Given this list of marker genes Pin1, Fam199x, Cldn12, Rnmt, Pwp1, Tnik, Wdr3, C1d, Wdr11, Rfx3, Zranb2, Pex7, Ppp2r1a, Hnrnpa1, Lsm7, Patz1, Ssbp1, Ppp4r3b, Prim1, Ttc9c, Ndufc2, Eri2, Trp63, Immp1l, E2f7, Appbp2, Bclaf3, Cenpf, Pspc1, Pbk, Hnrnpu, Pigf, Lsm5, Mbnl3, Tasp1, Zik1, Ska2, Mphosph8, Wee1, Snapin, Tmem230, G3bp2, Sap30, Gm42151, Ddr1, Ube2d2a, Actr3b, Srsf3, Plcb1, Ttf2, Smarca5, Nup85 (NCBI Gene Id 445007), Pabpc4l, Xpo1, Idh3a, Snrpb2, Trpm3, Snx5, Trappc2b, Cstf2, Itga2, Prr14l, Ctcf, Ndufa4, Ctnnd2, Hnrnpa2b1, Plekhb1, Rnf6, Bub1, Rragd, Ercc6l2, Eif4h, Esco2, Kbtbd8, Mcm2, Zfp532, Hnrnpdl, Ywhaq, Cdkl5, Tspan13, Cd38 (NCBI Gene Id 12494), Slc38a1, Bmi1, Sfpq, Anp32e, Paxbp1, Wif1, Zfp317, Chmp1b2, Kif16b, Car12, H2az1, Cnot6, Phf14, Fgfr1op2, Nvl, Rnf7, St6gal1, Zfp846, Chchd4, Tax1bp1, Tmem117, Ndufs4, Caprin1, Sesn3, Matr3, Itga6, Sbno1 (NCBI Gene Id 272223), Phb2, Bcl11a, Fam13b, Slc7a1, Zfp26, Akap9, Cfap97, Ncapg, Bcl2, Rbbp8, Stmn1, Syde2, Nudcd1, Cttnbp2, Jade1, Polr1c, Trdmt1, Fh1, Pacsin2, Sgo2a, Smchd1, Smndc1, Ncapd2, Rpl15, Ung, Cep164, Stard7, N4bp2, Ewsr1, Tcea1, Fignl1, Gpm6b, Rbbp5, Rad21, Cep43, Zfp362, Zfand6, Nfia, Xrcc5, Arl6ip6, Cep192, Eif4b, Hnrnpll, Edaradd, Tgfa, Zfp770, Sec22c, Fam76b, Acyp1, Arpp19, Kif2c, Cpsf6, Rbl1, Ndufc1, Moxd1, Map7d2, Ttc3 (NCBI Gene Id 70444), Rbak, Eftud2 (elongation factor Tu GTP binding domain containing 2), Polr2b, Rnf128, Hace1, Pcmtd2, Cryz, Cetn3, Paics (NCBI Gene Id 67054), Casp8ap2 (NCBI Gene Id 52376), Eps8, Ccna2, Zfp239, Neo1, Ik, Sema5a, Strbp, Edar, Mob4, Pdk1 (NCBI Gene Id 78869), Iftap, Mtdh (metadherin), Tmem209, Gtf2h2, Paip2, Atr, Smc4, Atad2, Uba2, Hars1, Topbp1, Usp1, Cep55, Hook1, Dbf4, Gemin6, Vdac1, Acat2, Ccdc90b, Met, Ankle2, Srsf10, Alg13, Pfn2, Zfp148, Zfp24, Emid1, Smim15, Mrps31, Rpa1, Cdc73, Vdac3, Nup107 (nucleoporin 107), Zfp422, Zfp160, Mrps33, Kctd15, Nfu1, Dpy30, Tomm70a, Uchl5, Shmt1, Prelid3b, Slc20a2, Trim59, Park7, Ssb, Usp34, Lrba, Ankrd26, Zfand4, Ahcyl, Utp15, Capza2, Chek1, Syncrip, Slf1, Gmnn, Rrm2, Ap1s3, Cdc25a, Efcab7, Ugdh, Pdzd8, Anapc1, Dnajc9, Sertad4, Vps26b, Ajuba, 2810004N23Rik (RIKEN cDNA 2810004N23 gene), Adgrl3, Oxct1, Nup155, Bub1b, Rnf44, Sgo1, Mllt3, Hnrnpa3, Dusp11, Ints2, Mrps18c, Rif1, Abhd13, Nol4l, Skp2, Gm14325, Rfc1, Top2a, Gm4739, Dnaja1, Hus1, Gtpbp10, Timm21, Trp53bp1, Phf6, Ublcp1, Eid1, Ppm1b, Ppat, Vps54, Cd24a, Ezh2, Crls1, Vbp1, Pola1, Auts2, Ing3, Ipo8 (importin 8), Melk, Adamts20, Dlat, Taf1d, Pcyox1, Lmbrd2, Orc5, Pkp4, Pus7l, Ect2, Rpa3 (replication protein A3), Setx, Med6, Pold3, Uhrf1, Arnt2, Mpzl1, Stk26, Rbm45, C630043F03Rik, A130010J15Rik, Nme7, Trmt6, Naf1, Enpp3, Mettl9, Actl6a, Sucla2, Cth, Dck, Ube2b, Calm2, Trmt11, Gsdme, Aurka, AU041133, D16Ertd472e, Ncapd3, Trps1, Prps2, Ift81, Col4a5, Parp1, Ahr, Tmem33, Ppip5k2, Serbp1, Trim37, Zfp367, Tceanc, Rad51, Rprd2, Aebp2, Farsb, Firrm, Nfyb, Dsg2, Cdca8, Rps6ka6, Shcbp1, Pcdh18, Lrrc40, Anln, Pot1a, Prom1, Trip13, Cdca7 (NCBI Gene Id 66953), Adk, Lcorl, Slc39a10, Strap, Cdc40, Tfrc, Kitl, Nanp, Zfp799 (NCBI Gene Id 240064), Ilf3, Grhl2, Tmpo, Hat1, Bbip1, Timm17a, Taf2, Rida, Spin1, Atxn1, Cav2, Tulp3, Stxbp6, Arap2, Polr3h, Actr6, Bet1, Zc3hav1l, Trappc10, Mthfd1, Mis18bp1, Nras, Kansl1l, Adh5, Col25a1, Pank1, Bcap29, Etfrf1, Ncbp1, Zfp955a, Tmtc4, Mme, Smc2, Asxl1, Zbtb44, Azin1, Rps3, Glrb (NCBI Gene Id 99751), Uba3, Depdc1a, Hells, Marchf6, Brca1, Zcchc8, 4931406C07Rik, Myb, Brd7, Tspan2, Wdr75, Ctdspl2, Nae1, Mdh1, Psat1, Zfp229, Trrap, Armc10, Rell1, Nek1, Cd2ap, Polr3k, Acsl3, Pds5b, Cdc6, Ywhab, Lamtor5, Atad1, Ptpn14, Rpe, Gpsm2, here is a description of the gene set: species: Mus musculus from publication Zhang M, Behbod F, Atkinson RL, Landis MD, Kittrell F, Edwards D, Medina D, Tsimelzon A, Hilsenbeck S, Green JE, Michalowska AM, Rosen JM (PMID 18559513) Using a syngeneic p53-null mouse mammary gland tumor model that closely mimics human breast cancer, we have identified, by limiting dilution transplantation and in vitro mammosphere assay, a Lin(-)CD29(H)CD24(H) subpopulation of tumor-initiating cells. Upon subsequent transplantation, this subpopulation generated heterogeneous tumors that displayed properties similar to the primary tumor. Analysis of biomarkers suggests the Lin(-)CD29(H)CD24(H) subpopulation may have arisen from a bipotent mammary progenitor. Differentially expressed genes in the Lin(-)CD29(H)CD24(H) mouse mammary gland tumor-initiating cell population include those involved in DNA damage response and repair, as well as genes involved in epigenetic regulation previously shown to be critical for stem cell self-renewal. These studies provide in vitro and in vivo data that support the cancer stem cell (CSC) hypothesis. Furthermore, this p53-null mouse mammary tumor model may allow us to identify new CSC markers and to test the functional importance of these markers. Genes up-regulated in cancer stem cells isolated from mammary tumors compared to the non-tumorigenic cells. Mouse Gene Set: ZHANG_BREAST_CANCER_PROGENITORS_UP